The following is a description of a gene set: Binding to DNA that is assembled into chromatin. Human Gene Set: GOMF_CHROMATIN_DNA_BINDING studied in species Homo sapiens, and this is the list of marker genes: KDM5A, APEX1, H1-8, HMGN1, TOX4, H3-3A, NR1H3, CHD4, HMGN4, WBP2NL, HR, CTCFL, H1-5, UTY, TOX, RUVBL2, MED1, ACTL6A, PITX2, PAX6, TOX3, FOXC2, SMARCC1, H1-4, ATRX, MYOG, SRF (NCBI Gene Id 6722), MTA2, GATAD2B, GRHL3, VAX2, OGT, CEBPB, BCL6, HNRNPC, RBBP4, NEUROG3, EP300, CLOCK, H1-0, NR1H2, CASC11, POLE3 (DNA polymerase epsilon 3, accessory subunit), ZNF276, H3-5, MACROH2A1 (macroH2A.1 histone), DHX9, MBD3, KDM4D, SMARCC2, H1-2, HSF1, CEBPA, EZH2, SMAD3, SMARCA4, CREBBP, FOXO3, AHDC1, HCFC1, TBR1, MYOD1, WBP2, HDAC1, INSM1, H1-10, NKAP, BAP1, H3-3B, PCBP2, HMGA2, THRA, ZIC2, NOTCH1, H3Y1, GRHL1, RELA, MACROH2A2, PPARGC1A, RUNX2, THRB, H1-9P, SMARCB1 (SWI/SNF related, matrix associated, actin dependent regulator of chromatin, subfamily b, member 1), RXRB, KDM6A, MSL2, REPIN1, HNRNPU, PER1, KDM3B, GATA1, SMARCD2 (NCBI Gene Id 6603), ZFX, HDAC3, H2AZ1, VRK1 (NCBI Gene Id 7443), HMGN5, HMGN2 (NCBI Gene Id 94860), ACTN4, RARA, ACTB, KDM6B, FOXO1, ATOH1, CTCF (NCBI Gene Id 10664), SBNO1, H1-7, HMGN3, H1-6, HDAC2, JMJD1C, GRHL2 (grainyhead like transcription factor 2), H1-3, RCC1, TOP1, MBD2, SBNO2, EOMES, KLF4, TOX2, SUZ12, KDM3A, SIRT6, PRDM14 (PR/SET domain 14), STAT3, XBP1, SMARCE1, H1-1, VAX1